The following is a description of a gene set: species: Homo sapiens Human Gene Set: GOBP_OLIGODENDROCYTE_DIFFERENTIATION The process in which a relatively unspecialized cell acquires the specialized features of an oligodendrocyte. An oligodendrocyte is a type of glial cell involved in myelinating the axons of neurons in the central nervous system., and this is the list of marker genes: BOK, NKX6-2, HDAC1, PTPRJ, SRSF1, SOX10, CTNNB1, B4GALT6, TMEM98, CERS5, TNFRSF1B, NKX6-1, PTN, PTPRZ1, MIOS, TNFRSF21, GSTP1, CD9, KCNJ10 (potassium inwardly rectifying channel subfamily J member 10), EIF2B2, CNTNAP1, ERCC2, CXCR4, CNP, SLC8A3, LPAR1, CNTN1, GPM6B, TPPP, CNTN2, WDR1, DLX1, NKX2-2, PLP1, NKX2-1, LYN, PRDM8, ID2, B4GALT5, BNIP3, SLC45A3, CSK, MTOR, TGFB1, PAX6, GSX2, EIF2B4, GPR17, DUSP15, SHH, NF1, RHEB, ID4, TRPC4, EIF2B5, HDAC2, OPALIN, MDK, TENM4, TSPAN2, CDK5, EED, MAG, MED12, OLIG1, OLIG2, IL34, DAG1, ERBB2, DUSP10, NCSTN (NCBI Gene Id 57297), SOX9, PRMT5, SOX8, PTEN, CCDC39, FA2H, SOX1, GLI3 (GLI family zinc finger 3), NSUN5, DLX2, ASCL1, MIR26A1, SUZ12, HES1, CERS6, DAAM2, VTN, CDKN2C, NOTCH1, CLU, CLCN2, NTRK2, EIF2B1, HES5, TP73, SOX11, EIF2B3, ZNF488, ZNF365, SOX13, NEUROD4, WASF3, ABCA2, SOX6, MAL, MYRF, QKI, DRD3